Given this list of marker genes Th, Ass1, Sms, Suclg1, Tat (tyrosine aminotransferase), Bhmt, Odc1, Dld, Pdhx, Sds, Farsb, Dlst, Pcx, Vars1, Adh1, Aoc3, Ppm1l, Glul, Tph1, Mmut, G6pc2, Got2, Aldh7a1, Bcat1, Glud1, Hal, Mpst, Pck1 (NCBI Gene Id 98888), Maoa, Tpo, Mccc1, Rars1, Ehhadh, Cad, Hadh, Ldha, Tdo2, P4ha2, Pnmt, Eprs1, Fah, Cs, Gpt2, Adh5, Arg2, Asns, Gclm, Gsr, Aldh18a1, Got1, Aldh1a1, Sdhd (NCBI Gene Id 97524), Sdha, Dbh, Hdc, Acss1, Pdk4, Hmgcs2, Gsta4, Adh7, Mars2, Acaa1a, Ogdh, Cbs, Ftcd, Acadm, Hibadh, Pkm, Fh1, Iars1, Pdha1, Pycr1 (pyrroline-5-carboxylate reductase 1), Cth, Hibch, Oat, Cps1, Adh4, Otc, Wars1, Idh1 (isocitrate dehydrogenase 1 (NADP+), soluble), Ddc, Gss, Srm, Hmgcl, Arg1, Auh, Mdh1, Hnmt, Acly, Prodh, Gls (NCBI Gene Id 98298), Aco2, Asl, Lars2, Mdh2, here is a description of the gene set: Amino acid metabolism Mouse Gene Set: WP_AMINO_ACID_METABOLISM species: Mus musculus